The following is a description of a gene set: Human Gene Set: FENG_SEPSIS_HIGH_RISK_ROS_DN from publication Feng A, Pokharel MD, Liang Y, Ma W, Aggarwal S, Black SM, Wang T (PMID 38674159) studied in species Homo sapiens, and this is the list of marker genes: JAK2, RHOU, GCLM, SOCS3, MSRA, ARG1, PECR, DNAJC4, CYP1B1, GSR, DNAJC5